The following is a description of a gene set: Mouse Gene Set: GOMF_L_LEUCINE_BINDING species: Mus musculus Binding to L-leucine, 2-amino-4-methylpentanoic acid., and this is the list of marker genes: Ubr2, Ubr1, Sesn3 (NCBI Gene Id 80293), Sesn2, Sesn1, Glud1